Given this list of marker genes ABCG8 (ATP binding cassette subfamily G member 8), RNU7-1, LDLRAP1, APOB, PCSK9, ENPP1, NOTCH1, NKX2-5, RNASEH2C, TREX1, RNASEH2A, LSM11, ADAR, LDLR, SLC34A2, IFIH1, SMAD6, ABCG5, RNASEH2B, GBA1, SAMHD1, GATA5, ABCC6, here is a description of the gene set: Calcification, that is, pathological deposition of calcium salts in the aorta. Human Gene Set: HP_CALCIFICATION_OF_THE_AORTA Calcification of the aorta studied in species Homo sapiens